Given this list of marker genes Pde1b, Wfdc17, Gabarapl2, Mt1, Ddit4, Adam19, Sult1a1, Pik3ip1, Tgfbi, Ifi205, Bin2, Gatm, Serinc3, Dnase1l3, Flot1, Ctss, Cd244a, Stx7, Ptpn1, Ifitm2, Sri, Tspo, Serpina3g, Ocstamp, Fkbp5, Pex11a, Sla, Apobec3, Ldha, Adpgk, here is a description of the gene set: Cytokines mediate cell-cell communication in the immune system and represent important therapeutic targets. A myriad of studies have highlighted their central role in immune function, yet we lack a global view of the cellular responses of each immune cell type to each cytokine. To address this gap, the authors created the Immune Dictionary, a compendium of single-cell transcriptomic profiles of more than 17 immune cell types in response to each of 86 cytokines (>1,400 cytokine-cell type combinations) in mouse lymph nodes in vivo. A cytokine-centric view of the dictionary revealed that most cytokines induce highly cell-type-specific responses. For example, the inflammatory cytokine interleukin-1β induces distinct gene programmes in almost every cell type. A cell-type-centric view of the dictionary identified more than 66 cytokine-driven cellular polarization states across immune cell types, including previously uncharacterized states such as an interleukin-18-induced polyfunctional natural killer cell state. from publication Cui A, Huang T, Li S, Ma A, Pérez JL, Sander C, Keskin DB, Wu CJ, Fraenkel E, Hacohen N (PMID 38057668) Mouse Gene Set: CUI_CDC1_OSM_RESPONSE_UP studied in species Mus musculus Genes positively differentially expressed in cell type: cDC1 (conventional dendritic cell type 1) upon treatment with cytokine: OSM in mouse lymph nodes in vivo.